The following is a description of a gene set: Genes predicted to be targets of miRBase v22 microRNA hsa-miR-6833-3p in miRDB v6.0 with MirTarget v4 prediction scores > 80 (high confidence targets). from publication Chen Y, Wang X (PMID 31504780) species: Homo sapiens Human Gene Set: MIR6833_3P, and this is the list of marker genes: ZNF701, ZNF398, CDKN2AIP, SYS1, ZNF28, USP10, RTN4RL1 (NCBI Gene Id 146760), PPP2R5B, B3GLCT, ZNF99, ZNF415, SLC30A7, CEP85L, ATF7IP, FAF2, FANCL, SERTM1, BCAT1, EPS8, ZNF90, TPM3, PPP3R1 (NCBI Gene Id 5534), TBCEL, PPP5D1P, DLAT, PHLPP1, ZNF257, TOB2, PTGES3, TMEM245, PLLP, GPATCH2L, ZNF611, ZNF808, CAVIN2, AQP9, ZNF420, DOK6, SIRT3, ZNF302, ZNF714, RBFOX2, LTN1, ZNF426, NFXL1, SPINK7, SENP3, ZFP1, UNC5C, RIN2, CHD5, PIP5K1B, TM4SF18, MBOAT2, DTWD2, SEC61B, SGMS1, MSI2, ZNF136, NXPH2, ALDH2, ACSM2B, SPOP, ZNF451, TCF12, ZNF268, ZNF721, AUTS2, MAP1B, MAFK, BTRC, TRAK2, SRP19, HAO1, ACSL3, ZNF57, IQCJ, ANKRD28, TGFBRAP1, RIMKLB, RNF148, TAB3, FOXK1, SH3TC2, ZNF708, PHYHIPL, PCSK2, SIKE1, ZFP14, CPEB4, MSL1, LSAMP, SLC4A8, KCNT2, IL20RB, LPGAT1, ACSM2A, ZCCHC8 (NCBI Gene Id 55596), ZNF208, TMEM178B, LDB2, ZNF558 (zinc finger protein 558), LACC1, ADAM10, RAB27B, VPS13C, ENC1, GATM, ZNF117, PTGR3, P2RY10, SAMD12, MYO3B, LONRF3, REEP3, PALM2AKAP2, ITGA4, ARL4C, DNAJB9, FRMPD4, PYURF, ZNF569, ZNF468, CADM2, VGLL3, ZNF655, ZNF844, PPP6R3, MID1, DLG3, ATP2A3, DCP1B, EMX2, ZNF705A, SEMA3A, KCNK6, ZBTB18, MTMR2, ZNF493, RAD54L2, ZBTB7A (NCBI Gene Id 56976), ZNF718, SLC12A6, TTC31, ZNF600, ADAMTS1, KIAA1191, ZFP36L1, ZNF135, ZNF181, MARK1, IL17RD, DENND2C, STON2, EP300, PPARGC1B, CLMP, ZNF816, ZNF761, DDI1, SNX13 (NCBI Gene Id 23161), FAM78A, MAP3K2, CYB561D2, SEC24C, PLXNA2 (plexin A2), ZNF189, THG1L, PMEPA1, C11orf58, ADAM22, ZNF138, VANGL1, ZFP90 (NCBI Gene Id 146198), KCNJ3, NDUFC1, MEX3A, SSUH2, SPRY3, NEURL1B, ZNF317, GALNT15, CUL3, SH3PXD2A, ZNF711, GYPE, CASP3, RNF213, CDR2L, MBNL1, CDK6, CDH19, TNRC6B, ZFHX2, USP37, HLA-DOA, NF1, HOXC6, RPS6KA6, IDE, SLC7A11, MOB1B, ZSWIM6 (NCBI Gene Id 57688), SPTSSB, RIMBP2, FAM120A, PPRC1, NEDD4L, ZNF682 (zinc finger protein 682), ZNF562, KMT2A, GTDC1, ARF6, B3GALNT2, ENTPD1, ZNF728, SRXN1, ZMYND8, TPT1, SYNJ2BP, ANKH, ZBTB20, P2RY4, OR51E2, DCX, SLC6A2, RSBN1, VIP, ZNF37A (NCBI Gene Id 7587), STRBP, GCFC2, PLXNA4 (NCBI Gene Id 91584), SMIM14, ZNF713, GNB1, CLVS2, HDAC8 (NCBI Gene Id 7492), CDK12, CNR1, SLC5A12, ZNF626, NNT, ZNF676, KCNAB1, SCAI, PSD3, EVC, FCAR, PGF (NCBI Gene Id 5228), DENND4A, RBMS3, TMEM151B, PLD5, ZDHHC3, HNMT, ZNF91, ZNF845, ZSCAN22, CALML4, MEF2A, ABCC9, PPM1L, TREML4, SLC17A3, ARL15, NFIX, CNIH1, PIP4K2B, TRIM71, UHMK1, ONECUT2, PDE4D (NCBI Gene Id 654081), SLC25A24, ADGRF1, ZNF124, CNNM4, GPC6, LRRC7, ZNF502, DTNA, ASCL1, ZNF705D, CEMIP, MAP2, SLC6A11, SNX18, TBL1XR1, AAK1, ZNF544, MBNL3, SOBP, CDON, PAPPA, KCNC2, TMEM87A, SELENOT, ZNF730, CHD9, PIGY, ENPP1, BLZF1, CD44, ZNF107, SBNO1, SLC8A3, KCMF1, SHISA6, COPS6, FOXA1, ZNF195, SYNPO2, TCHHL1, ARK2C (NCBI Gene Id 494470), ZNF559, ANO3, KRIT1, ZNF716, CSGALNACT2, PURA, DGKG, SHISA9, SFTPB, PEG10, RHOQ, ATP8A1, GSE1, DIRAS3, DSG3, TOR1AIP1, MYCL, POTEM, GPR3, FAM131B, PARD3B, IKZF1, ZNF559-ZNF177, TMEM170B, ZNF763, CDNF, RAPH1, CLEC4A, ZNF791, CALU, RDH12, RPP30, ZNF578, ZFP62, ZNF557, BCL11A, PRKCB, FUT9, EGR3, PDK3, CCDC88A, ZNF765, MSS51, SHOX2, KLHL5, PRTG, LENG8, SLAIN1, BCLAF1, ZNF813, DDX19A, FMN1, SMIM21, BNC2, ZNF888, PAK2, C22orf46P, MAGI3, SLC22A15, C1QTNF3 (C1q and TNF related 3), ZNF440, POU2F2, ZNF670, AP4E1, TRIM9, MYT1, ZNF207, EDA, CNKSR2, LRP4, KIAA1549L (NCBI Gene Id 25758), SNTG1, LGSN, ELMO2, ZNF439, ATP6V1C1 (ATPase H+ transporting V1 subunit C1), GCLM, SLC38A1, WDR33, ZNF594, FGF23 (fibroblast growth factor 23), LPP, ADRB2, TAF11, PATE1, LTA, QRSL1, PDE7B, TSC22D2, SLAIN2, SLC39A8, ZFP37